The following is a description of a gene set: species: Mus musculus Mouse Gene Set: GOBP_REGULATION_OF_INHIBITORY_SYNAPSE_ASSEMBLY Any process that modulates the frequency, rate or extent of inhibitory synapse assembly., and this is the list of marker genes: Clstn3, Sema4d, Sema4a, Lhfpl4, Cbln1